Given this list of marker genes AKR1C2, CYP39A1, SLC27A5, SLC27A2, CYP8B1, HSD3B7, AKR1D1, AKR1C1, CYP27A1, AKR1C4, AMACR, AKR1C3, CYP46A1, here is a description of the gene set: studied in species Homo sapiens Synthesis of bile acids and bile salts via 24-hydroxycholesterol Human Gene Set: REACTOME_SYNTHESIS_OF_BILE_ACIDS_AND_BILE_SALTS_VIA_24_HYDROXYCHOLESTEROL